Given this list of marker genes Crkl, 4930579K19Rik (NCBI Gene Id 75881), Iqcf1, Ggt7, Cd2ap, Tia1, Aff3, Calcoco1, Ackr3, Igkv4-70, Nudt12, Psors1c2, Trbv14, Catsper3, 4930572K03Rik, Chchd5, Gjb2, Gsdmc, Gstm1, Clybl, Plekhm2, 1110002E22Rik, C030013G03Rik, Uck2, Reln, Cxcl16, Hgd, Mcm4, 4930562C15Rik, Kif6, Prdx6-ps2, Ramp2, Ube2d2b, Fmo5 (NCBI Gene Id 99564), Lgals2, Stom, Tnfrsf12a, Prss3b, Etaa1os, Prkx (protein kinase, X-linked), Ttn, Actl6b, Serpinh1, R3hcc1l, Tex26, Rinl, Egln3, Gpr37, Slc38a10, Ptx4, Cyp3a11, Kpnb1, Krtap6-5, Hand1, Sox4, Xdh (NCBI Gene Id 22436), Siglecf, Muc2, Abhd14b, Mfap3l, Dyrk1a, Nek4 (NIMA (never in mitosis gene a)-related expressed kinase 4), Tmod1, Col20a1, Igkv4-55, Tchhl1, Them5, Smim33, Atg2a, Morn5, Traf2, Cd2, Nr6a1, Mxi1, Zscan2, 2900064F13Rik, Gm3696, Trpc6, Man2a2, 4930557J02Rik, Xpc, 2310026I22Rik, Prrt1, Zfp787, 1700095A13Rik, Lim2, Dock4, Lag3, Potegl, Rgs14, 4930556N13Rik, Sgta, here is a description of the gene set: Genes that classify progression risk of benign papilloma samples: low vs high risk. Chemical induction of squamous tumors in the mouse skin induces multiple benign papillomas: high-frequency terminally benign low-risk papillomas and low-frequency high-risk papillomas, the putative precursor lesions to squamous cell carcinoma (SCC). We have compared the gene expression profile of twenty different early low- and high-risk papillomas with normal skin and SCC. Unsupervised clustering of 514 differentially expressed genes (P<0.001) showed that 9/10 high-risk papillomas clustered with SCC, while 1/10 clustered with low-risk papillomas, and this correlated with keratin markers of tumor progression. Prediction analysis for microarrays (PAM) identified genes that distinguished the two papilloma classes, and a majority of these had a similar expression pattern in both high-risk papillomas and SCC. Additional classifier algorithms generated a gene list that correctly classified unknown benign tumors as low- or high-risk concordant with promotion protocol and keratin profiling. Reduced expression of immune function genes characterized the high-risk papillomas and SCC. Immunohistochemistry confirmed reduced T-cell number in high-risk papillomas, suggesting that reduced adaptive immunity defines papillomas that progress to SCC. These results demonstrate that murine premalignant lesions can be segregated into subgroups by gene expression patterns that correlate with risk for malignant conversion, and suggest a paradigm for generating diagnostic biomarkers for human premalignant lesions with unknown individual risk for malignant conversion. from publication Darwiche N, Ryscavage A, Perez-Lorenzo R, Wright L, Bae DS, Hennings H, Yuspa SH, Glick AB (PMID 17525749) species: Mus musculus Mouse Gene Set: DARWICHE_PAPILLOMA_PROGRESSION_RISK